The following is a description of a gene set: studied in species Homo sapiens Human Gene Set: KEGG_MEDICUS_REFERENCE_CXCR4_GNA12_13_RHO_SIGNALING_PATHWAY Pathway Definition from KEGG: CXCL12 -> CXCR4 -> GNA12/13 -> (ARHGEF12,ARHGEF1) -> RHOA -> ROCK1/2 CXCR4-GNA12/13-Rho signaling pathway. Pathway ID: N00405. Pathway type: Reference. Pathway class: nt06167 Human cytomegalovirus (HCMV)., and this is the list of marker genes: RHOA, ROCK1, ROCK2, ARHGEF1, CXCL12 (NCBI Gene Id 6387), GNA13, CXCR4, GNA12, ARHGEF12